The following is a description of a gene set: Any process that results in a change in state or activity of a cell or an organism (in terms of movement, secretion, enzyme production, gene expression, etc.) as a result of a starvation stimulus, deprivation of nourishment. studied in species Homo sapiens Human Gene Set: GOBP_RESPONSE_TO_STARVATION, and this is the list of marker genes: FBXO22, MAPK8 (mitogen-activated protein kinase 8), SREBF1, MYH13, PIK3C3 (NCBI Gene Id 5289), GPR155, SEH1L, UCP2, PRKAG1, SLC7A5, MICU1, RPTOR, WIPI1, RNF167, WNT2B, FOXK1, MAP1LC3B, CDKN1A, GIP, ULK2, MFSD2A, LRP11, BCL2, WDR24, GCGR, PAK2, GALP, DEPDC5, SRD5A1 (NCBI Gene Id 6715), GLUL, TSC1, MAPK1 (mitogen-activated protein kinase 1), KRT20, RALB (NCBI Gene Id 5899), STK26, XBP1, PRKAA2, BECN1, PAK4, FNIP1, SP1, ALB, MTMR3 (NCBI Gene Id 8897), PRKAG3, EIF2AK2, HSPA8, SLC2A1, SFRP1, PCK2, OXCT1, KAT5, ATF4, RRAGD, ELAPOR1, MAP3K5, WDR45, PAGE4, PLIN3, YARS1, CLEC16A, SLC39A5, PAK3 (p21 (RAC1) activated kinase 3), SAMTOR, RIPOR1, SZT2, PCSK9, MIOS, NPRL3, ULK1, ZC3H12A, ATG14, TBC1D7, CARTPT, PLIN2, UPP1, MYOD1, MAP1LC3B2, WDR45B, BECN2, AMBRA1, PRKCH, KPTN, ADSL, VPS41, ZFYVE1, YME1L1, PCK1, XPR1, BHLHA15, KLF10, MCU, EIF2AK1, PIK3R4, CADPS2, HCRT, FOXO1, RRP8, SLC38A3, ATG5, HNRNPA1, EIF2S1, HFE, ZFP36, BMPR2, PPM1D, BGLAP, TP53, YWHAZ, MAP1LC3A, PAK6, AKR1C3, SIRT1, RRAGA, ACAT1, FOXO3, LAMP2, EIF2AK4, EIF2AK3, TTC5, CPEB4, FOXK2, PICK1, FOS, SH3GLB1, PMAIP1, WDR59, TBC1D5, SAR1B, SP7, USP33, PDK4, SESN1, SUV39H1, EHMT2, IMPACT, CHKA, CBL, GABARAPL3, GABARAP (NCBI Gene Id 201246), HRK, MAP1LC3C, ATG7, YWHAG, PIK3C2B, NFE2L2 (NFE2 like bZIP transcription factor 2), MAPK3, PRKAA1, NUPR2, SESN2, TBL2, DNAJC15, ACADM, CPS1, PPARA, TNRC6A, MTOR (mechanistic target of rapamycin kinase), MYBBP1A, ATXN3, LARS1, LARP1, CAD (carbamoyl-phosphate synthetase 2, aspartate transcarbamylase, and dihydroorotase), UCN3, WNT9B, DELE1 (NCBI Gene Id 9812), GCN1, DDIT3, SMDT1, BNIP1, PRKAG2, SLC38A2, RRAGC, SLC34A1, ATF2, HIGD1A, GBA1, WIPI2, ULK3, WNT4, ITFG2, GABARAPL2 (GABA type A receptor associated protein like 2), WRN, RRAGB, BCAS3, FADS1, HMGCS2, PPARGC1A, TSC2, PAK1, KICS2, SSTR1, NPRL2, HSPA5, GAS2L1, FLCN, COMT, RNF152, SREBF2, ASNS, PEX2, GABARAPL1, INHBB, CAV1, EIF2A, LRRK2, PAK5, IFI16, TFEB, GAS6, ATF3, ADSS1, TNFRSF11A, DSC2, FOXA3, PRKD1, SAR1A, JMY, TRIM32, CASTOR1 (NCBI Gene Id 652968), FAS, SLC39A4, NUAK2, SESN3, STK24